Given this list of marker genes Gm30008, Mir124a-1, Trim13, Rps12-ps2, Nefl, Gm24981, Prss51, Gm41168 (predicted gene, 41168), Defb30 (NCBI Gene Id 78130), Ctsb, Ccdc25, Gm25162, Spryd7, Adam7, Gm18146, Trim35, Elp3, Gm6913, Mir3078, Ints9, Gm17116, Fam124a, Gm47256, Gm9086, Gm9570, Prss55, 4930438E09Rik, Amer2, Gm46476, Gm10233, Ephx2, Gm22319, Bnip3l, Gm26225, Wdfy2, Cdca2, Dock5, 4930578I07Rik, 1700109G14Rik, Gm41183, Pinx1, Adam2, Mir6539, Ppp2r2a, Fdft1, Pnma2, 4930563I02Rik, Gm9013, Gm20675, 4930556J02Rik, Gm19216, Defb43, Gm38409, Pnoc, C1qtnf9, Gulo, Ints6, Gm41177, Gm6076, Mir8098, 9630015K15Rik, Neil2, Nup58, Rp1l1, 1700001G11Rik, Xkr6, Gm4573, Gm24625, Gm6066, Gm23629, Dleu2, Ebpl, Ptk2b, Sgcg, 4930471C04Rik, Kcnrg, Rnaseh2b, 4930578I06Rik, Gm19198, Mir598, Gm21430, Spata13, Kpna3, Adamdec1, Prss52 (NCBI Gene Id 73382), Adra1a (adrenergic receptor, alpha 1a), Sox7, Gm27017, Gm17941, Hmbox1, Gm30806, Msra, Gm6878, Gm35419, Gm21021, Gm16261, Gm31227, Dpysl2, Arl11, Mir6541, Adam28, Sacs, Mtmr6, Gm4118, Nefm (neurofilament, medium polypeptide), Kctd9 (potassium channel tetramerisation domain containing 9), Clu, Tnfrsf19, Tdh, Dleu7, Defb47, Gm29266, Mir16-1, Mipepos, Defb42, Gm10860, Scara5, Gm9130, Vmn1r-ps136, Nuggc, Gm15918, Pbk, Serpine3, Gm17232, Chrna2, Atp8a2, Kif13b, Gm19097, Zfp395, Gm35595, Gm20111, Blk, Gm48449, Gm24258, Fbxo16, Extl3, Mipep, Gm31107, Defb48 (NCBI Gene Id 432867), Fam167a, Gm5461, Fzd3, Mir124a-1hg, Gnrh1, Mtmr9, Ebf2, Gm5464, Scara3, Mir15a, Gm10032, Esco2, Gata4, Gm4131, Gucy1b2, Stmn4, Gm19222, Mir719, here is a description of the gene set: species: Mus musculus Mouse Gene Set: chr14D1